Given this list of marker genes Chrnb2, Pink1, Stx1a, Rtn4, Cartpt, Npy2r, Plcd1, Pcp4, Slc18a1, Cxcl12, Htr6, Grk2, Kcnb1, Oxtr, Oxt, Adora2b, Syt1, Oprk1, here is a description of the gene set: Mouse Gene Set: GOBP_POSITIVE_REGULATION_OF_CATECHOLAMINE_SECRETION Any process that activates or increases the frequency, rate or extent of the regulated release of a catecholamine. species: Mus musculus